Given this list of marker genes BMX, PIGH, MTMR2, PIGB, PIP5K1C, PIK3CG, PLCB3, PLCH2, IMPA1, INPP5K, PTEN, PDGFA, DPM3, IP6K3, PGAP4, AGPAT5, PIK3C2A, IPMK, INPP5J, INPP4A, PI4KA, PIPSL, PLCL1, PLCB1, PITPNM1, PDGFB (platelet derived growth factor subunit B), DPM2, VAC14, PIGC, MTMR12, PTPRQ, TTC7A, BPNT1, FIG4, PLA2G4D, PIGA, CWH43 (cell wall biogenesis 43 C-terminal homolog), CDIPT, PIP4K2B, PIP4K2C, ATM, PLA2G4E, PIP4P2, PIGW (phosphatidylinositol glycan anchor biosynthesis class W), MTMR14, PIGL, ITPKC, PLCL2, PIGG, PIP5KL1, LPGAT1, BECN1 (beclin 1), SYNJ1, PI4KAP2, PIGS, PGAP3, PIK3R5, SACM1L, PIP4P1, MTMR1, PIGF, ATG14, PIGY, IP6K1, INPPL1, PIGV, PIK3C2B, INPP1, PIK3CB, PIK3C3, PLCD1 (NCBI Gene Id 5333), MTMR7, PIK3R1, PI4K2B, OCRL, ITPKB, PIGK, LCLAT1, MTMR8, DGKE, SH3YL1, PIGX, INPP5E, MTMR4, PI4KB, PIGO, EFR3A, PIGM, MTM1, TNFAIP8L3, BPNT2, INPP5F (inositol polyphosphate-5-phosphatase F), GPAA1 (glycosylphosphatidylinositol anchor attachment 1), PLCG2, INPP5B, PIK3R3 (NCBI Gene Id 8503), PIGN, PIKFYVE, PITPNM2, INPP5D, HYCC2, HTR2B, PIGU, ITPKA, PLCB4, MTMR10 (NCBI Gene Id 54893), MPPE1, CDS1, IMPA2, MTMR11, IP6K2, PIK3CD, DPM1, PIGQ (phosphatidylinositol glycan anchor biosynthesis class Q), PIGT, PITPNM3, MBOAT7, HYCC1, TMEM150A, UVRAG, MTMR6, CHRM5, EFR3B, PI4K2A, SYNJ2, PIP5K1B, SLC30A5, PLA2G3, PIP4K2A, PLCG1, TTC7B, PIK3CA, HTR2C, PIK3R4, INPP5A, HTR2A, PIK3C2G, GALR2, PGAP2, PIGP, INPP4B, MTMR3, PIP5K1A, PIGZ, PGAP1 (NCBI Gene Id 80055), DDHD1, MTMR9, PLCE1, SMG1, TPTE2, PLCB2, PLCH1, here is a description of the gene set: The chemical reactions and pathways involving phosphatidylinositol, any glycophospholipid in which a sn-glycerol 3-phosphate residue is esterified to the 1-hydroxyl group of 1D-myo-inositol. Human Gene Set: GOBP_PHOSPHATIDYLINOSITOL_METABOLIC_PROCESS studied in species Homo sapiens